Given this list of marker genes COL13A1, CHAT, SNAP25, MYO9A, SLC25A1, HTT, SLC5A7 (NCBI Gene Id 60482), KCNT2, KCNQ2 (potassium voltage-gated channel subfamily Q member 2), SCN2A, PRRT2, AARS2, NGLY1, ATXN1, SLC18A3 (solute carrier family 18 member A3), SYNJ1, NEXMIF, SYT2, PNKD, AGRN, VAMP1, SLC2A3, here is a description of the gene set: An abnormality in which the eyes are held permanently wide open. Human Gene Set: HP_STARING_GAZE Staring gaze species: Homo sapiens